Given this list of marker genes ZFP36, ERBB4, TMPRSS4, CRB2, ADGRL1, here is a description of the gene set: species: Homo sapiens from publication Chen Y, Wang X (PMID 31504780) Human Gene Set: MIR551A_MIR551B_3P Genes predicted to be targets of miRBase v22 microRNA hsa-miR-551a, hsa-miR-551b-3p in miRDB v6.0 with MirTarget v4 prediction scores > 80 (high confidence targets).